Given this list of marker genes TMED10, PREB, SEC22B, SERPINA1, CNIH1, CNIH3, MIA2, MIA3, SEC24D, SEC24C, F8, FOLR1, CTSZ, COL7A1, LMAN1L, GOSR2, STX5, SEC24B, CTSC, GRIA1, MCFD2, AREG, TGFA, LMAN2L, SEC23A, CD59, LMAN2, LMAN1, CNIH2, SAR1B, SEC24A, TMED2, F5, here is a description of the gene set: studied in species Homo sapiens Computational analysis suggests that ~25% of the proteome may be exported from the ER in human cells. These cargo need to be recognized and concentrated into COPII vesicles, which range in size from 60-90 nm, and which move cargo from the ER to the ERGIC in mammalian cells. Recognition of transmembrane cargo is mediated by interaction with one of the 4 isoforms of SEC24, a component of the inner COPII coat. Soluble cargo in the ER lumen is concentrated into COPII vesicles through interaction with a receptor of the ERGIC-53 family, the p24 family or the ERV family. Each of these families of transmembrane receptors interact with cargo through their lumenal domains and with components of the COPII coat with their cytoplasmic domains and are packaged into the COPII vesicle along with the cargo. The receptors are subsequently recycled to the ER in COPI vesicles through retrograde traffic. Packaging of large cargo such as fibrillar collagen depends on the transmembrane accessory factors MIA3 (also known as TANGO1) and CTAGE5. Like the ERGIC, p24 and ERV cargo receptors, MIA3 and MIA2 (also known as CTAGE5) interact both with the collagen cargo and with components of the COPII coat. Unlike the other cargo receptors, however, MIA3 and MIA2 are not loaded into the vesicle but remain in the ER membrane. Reactome Pathway: Cargo concentration in the ER part of: ER to Golgi Anterograde Transport